Given this list of marker genes MIR762HG, RPL37, TRIAP1, NSA2, PSMC2, NDUFS3, ANO8, ZMPSTE24, AOC2, PSCA, BCL9, CFAP20DC-AS1, SSBP4, ARID4B, POLR2A, VPS13B-DT, MTMR9, ZNF260, TBC1D19, MALT1, CCDC88A, SPNS1, ZBTB4, AVPR1B-DT, PLEKHM3, C12orf76, NUDT19-DT (NUDT19 divergent transcript), VPS13B, NCOR1, TMEM101, EFCAB7, MT-ND6, ZNF404, LINC00687, CYP4F3, AGGF1 (NCBI Gene Id 55109), FAM227B, SMG5, PHIP, DCP1A, DISC1, INTS5, SNUPN, RELA, CASP7, ANKRD18DP, TPSB2, ABCA15P, CYREN, CENPW, ZNF225-AS1, COX16, CNIH3-AS2 (NCBI Gene Id 102723817), HYOU1, RPS19 (NCBI Gene Id 8378, ribosomal protein S19), ATP5MC1, ANKRD46, TRADD, MRM3, THAP10 (NCBI Gene Id 56906), TEFM, ACOX1, MCM3AP, DSN1, NKAPP1, FAAH, STN1, ZDHHC12-DT, VWA8, RNF6, LAMA3, BMS1P4-AGAP5, CD6, SREK1IP1, LDAF1, GOSR1 (golgi SNAP receptor complex member 1), P3H2-AS1, IPO4, GLIPR1L1, TBC1D9B, MT-ND1 (mitochondrially encoded NADH:ubiquinone oxidoreductase core subunit 1), ENSG00000253163, RNVU1-15, TM6SF2, BCKDK, S100A2, TRIM2, USPL1, RSAD1, EPB41L4A-AS1, JPX, C4orf3, SNCA, RGS5, RNU11, DPP9, OCRL, SLC7A5P1, LINC01547, MCF2L, WDR26, CDC42SE1, ZNF780A, CYP3A5, BMP7, TMC5, MTND5P11, SLX9, RSPH4A, MDN1, TMA16, ZNF136, ZBTB40, PKIB (NCBI Gene Id 5570), RNU6-883P, ZNF821, GLOD4, MIR6763 (microRNA 6763), USP30, PAQR4, RGL2, MRPL44, HDAC2-AS2, ENSG00000267174, CDK1, NFX1, FAM228B, TDRKH, PRRT3-AS1, LINC00494, UQCC6, HIPK3, EIF1AD, SSBP1 (NCBI Gene Id 6742), WDR11-DT, AKAP10, VPS52, GBA1, MICALL2, TMEM161A, INTS12, SURF4 (surfeit 4), STAT3, DDX55, ADAMTSL4, CWC27, UBAC2-AS1, PKMYT1, DNAJC2, ADGRL1, EXD3, CDK5RAP1, SLC39A3, PUS10, TMC7, TPSD1, HSD17B11, ATP11AUN, TMEM127, NDUFAF1, MARK4, PDCD10, PWWP3A, CFAP298 (cilia and flagella associated protein 298), ATAD2, CERNA3, MRPL21, MAN2C1, SAT2, KLHL12 (kelch like family member 12), KIF2A, ANKRD40, OTUD7B, BCL7C, MT-TT, FUT10, MTF2, ADAP2, AAR2, CCNH, SNORA13, VTA1, COX11, ATP8B2, MAP3K6, SPAG4, KIF1B, GABPB2, FAM234B, ZNF688, HMGB3P22, IGHMBP2, SERP1, AARS2, CYP4F11, ABCD2, NOXA1, FZD3, GTPBP3, TEN1, RPS7, SEC22B, MALT1-AS1, ZNF461, RPS12, ZKSCAN4, CFAP298-TCP10L, CEBPG, ZNF133, CANX, CFD, TMEM242-DT, GALNT13, SLC41A1, ADAT2, COPS7B, STKLD1, STOML1, SAR1B, OSBP2, DSTYK, BORCS8-MEF2B, PDCD6P1, PPP4R3A, COG2, POLR3GL, NSL1, C17orf75, SLCO4A1-AS2, SLC44A1, FAT3, SLC41A2, CGGBP1, PRKCI, RFXANK, POLR3K (RNA polymerase III subunit K), RAB4B-EGLN2, FANCC, SUPT3H, UBE2J1, TRDMT1, HRK, NGFR, SMG8, RAB9A, ADPGK, TARS3, IL21R, EIF2AK4, GFM2, TRIP4, RN7SL346P, BDKRB2, MKRN2, PIGN, PCLAF, ZNF518A, MAPK8IP3, ZNF846, STUM, ALKBH3, CNIH3, CCAR2 (NCBI Gene Id 57805), RAB30, GRB2, ZNF579, POLDIP3, TARS2, CDK12, MTX3, ZNF227, HECTD1, MYO1B, ZNF276, TNIP1, RPS20, NPTX1, MST1P2, CUL4A, TMEM30A-DT, ENSG00000267058, AURKAIP1, KCTD5, CROCCP2, TOR1AIP1, MYO15A, TMEM9B-AS1, SARS2, SF3A3, TSEN15, RNA5SP200, SLC25A23, MTCO3P12, RPL27, ADGRB3, RFLNA, FAM98B, RWDD1, SMIM8, ANKRD18A, DNAJC25-GNG10, LHFPL7, B4GALT6, MAPK14, REX1BD, LDLR, TEN1-CDK3, SMOX, MAFB, KHDC1, AP3S1 (adaptor related protein complex 3 subunit sigma 1), MYO1B-AS1, FOXO1B, EIF4EBP2P2, LINC02985, DAGLB, TACO1, TMEM120B, SLC25A13, HDGF, MIR1302-3, GIN1, MT-TE, KCTD10, GULP1, ATG12, ISLR2, ITFG2, POLR3C, ZNF540, LINC02846, JMJD1C, ZC3HC1, COMMD10, WEE2-AS1, MTR, SLC38A4, IFI6, PLD3, ZFYVE9, KMT2A (lysine methyltransferase 2A), RBBP5, SNRPB, SNHG11, SLC25A42 (NCBI Gene Id 57831), EXD2, NUMA1, THBS4, KCNMA1, MRPS31, PIWIL4, UNC80 (NCBI Gene Id 84540), TNIP2, MIX23, CMTR1, REXO4, ZFP14 (NCBI Gene Id 57677), PAFAH2, ZSCAN16-AS1, ZNF790, MRPS31P5, LINC00322, PSD, VPS9D1, TMEM79, QRICH1 (NCBI Gene Id 54870), SHBG, SNORD54, ISYNA1, ARID1A, LNPEP (NCBI Gene Id 4012), SAMD4B (sterile alpha motif domain containing 4B), ITGB3BP, WDR11, NME1-NME2 (NCBI Gene Id 654364), ZNF786, SNRNP25 (small nuclear ribonucleoprotein U11/U12 subunit 25), GLUD1P3, WDR36, TDRKH-AS1, KANK2, NVL, TAF1C, NBPF1, ALG9, VTRNA1-3, RPS4X, TMEM69, PPFIA3, ENPP3, CFAP52, CAMK2G, LINC01275, GTF3C3, RNU7-80P, GDAP1, DNAH2, PACSIN3, ZNF165, SOCS2, PLIN3, SYNPO2, ASAP1, CLIP1, TMEM242, CDC16, MSL1, LINC01719, SNHG5, STXBP4, TPSAB1, YBEY, ADGRE2, ST6GALNAC2, BANF1 (barrier to autointegration nuclear assembly factor 1), LRRC37A5P, FAM201A, STX16-NPEPL1, GARRE1, SERPINI1, YAP1, TRPM7, FCGRT, RUFY2, ENSG00000237101, PFKL, VPS36, B4GALNT1, GPBP1L1, DTWD1, BORCS7-ASMT, VPS51 (NCBI Gene Id 739), GGPS1, BPIFA2, RPL6, MANEAL, COLGALT1, TATDN3, RGS16, GSTCD, WTIP, LRRC49, ERCC8, C19orf47, STX8, DMAP1, RAB4B, GRSF1, DST, STX16, INTS14, PIGL, ZNF724, ZNF566-AS1, SLC37A3, SPRYD7, MTIF2, MKNK2, RNF115, TMEM9B, MAILR, C3orf38, SRP54-AS1, PKM, RAI1, RCAN1, SRP54, ZMPSTE24-DT, COQ8A, RNVU1-27, RDH14, GEMIN8P1, DGUOK, GALNT16-AS1, ZDHHC12, BORCS8, XNDC1N, ZMYND8, HDAC2, IFT46, RNF121, ASH2L, BORCS7 (NCBI Gene Id 119032), LRRC51, GATC, MIA3, ALDH3A1, GCN1, NDUFAF2, NDUFS7, PBK, ORMDL3, RAD52, BMS1, SF3B6, HNRNPFP1, TUBGCP3, PLXNB3, ENSG00000232995, OSBPL2, PFKP, NT5DC3, STIL, HROB, FOXJ3, GHET1, PPIP5K2, C16orf95-DT, ZNF225, CXorf58, ARHGEF28, MIR4519, CDK11A, PEX3, DNAJC25, LINC00240, IFTAP, RPS18, CDKN2AIPNL, ITFG2-AS1, ATP5F1B, AZIN1, MAX, KBTBD4, ZNF391, LSG1, RAB30-DT, ZBTB38, NME1, RSRP1, MED23, RSRC1, SH3PXD2A-AS1, AVPR1B, BMS1P4, TEX53, IFT56, PKN1 (NCBI Gene Id 5585), LINC01778, SLC35A3, HSP90AB1, SLC24A1, TMEM30A, PDE6D, TRIB1, ST7, VWA8-AS1, NACC2, FUT4, MT-TL1, NUF2, C18orf21, LCA5, HES1, LINC01775, RELCH, SREBF1, LRP12, DUSP6 (dual specificity phosphatase 6), CCDC57, JRK, RNF220, FAM162A, ANKRD34A (ankyrin repeat domain 34A), RC3H2, IST1, HMGB1, NEK3, EIF2D, P3H2, TMBIM4, FRA10AC1, NR2F1-AS1, HPN-AS1, PEX13, PRPF40B, BLOC1S6, LINC02695, ELOA-AS1, AP3S2, NUP205, PCID2, TOMM6, TTI2, CNTNAP2, RNY1, SRFBP1 (NCBI Gene Id 153443), PIK3R1, ITIH4, ZNF45-AS1, here is a description of the gene set: studied in species Homo sapiens from publication Yevshin I, Sharipov R, Kolmykov S, Kondrakhin Y, Kolpakov F (PMID 30445619) Genes containing one or more binding sites for (ZNF329) in their promoter regions (TSS -1000,+100 bp) as identified by GTRD version 20.06 ChIP-seq harmonization. Human Gene Set: ZNF329_TARGET_GENES